The following is a description of a gene set: species: Homo sapiens Human Gene Set: GOMF_MODIFIED_AMINO_ACID_BINDING Binding to a modified amino acid., and this is the list of marker genes: FASN, MMUT, TRIM72, GSDMC, APPL2, FOLR3, SYT5, MFGE8, OSBPL10, GSDMB, ANXA9, SMPD3, ANXA11, UROS (NCBI Gene Id 7390), JPH2, THBS1, MGST2, SYT1, OSBPL5, TYMS, DPEP1, CBS, GSTM1, NOX4, PLEKHN1, GPR143, ANXA5, ANXA2P2, RPE65, SLC19A1, AXL, ANXA13, ANXA1, ENSG00000274276, GSTM4, GAP43, MTHFS (NCBI Gene Id 10588), PTGES, SCARB1, MME, TIMD4, APPL1, DHFRP1, ANXA7, ANXA3, FTCD, GRAMD1B, ANXA4, MMACHC, CPS1, SCIN, ANXA8, FOLR2, SESTD1, IZUMO1R, ANXA6, HAVCR1 (NCBI Gene Id 26762), PLCD1, GSTM2, ADGRB1, OSBPL8, CD300LF, CPNE1, GSDMD, GAS6, RS1, MTHFR, TREM2, ANXA10, PTGES2, SLC46A1, FTCDNL1, HMGB1, SYTL2, DHFR, SYT9, CPNE6, CAVIN2, MARK1, FCHO2, GNMT, SYT10, GSDMA, GSS, CD300A, LANCL1, ANXA8L1, FOLR1 (NCBI Gene Id 2348), ANXA2, TLN1, SCARB2, GSTM3